The following is a description of a gene set: Genes predicted to be targets of miRBase v22 microRNA hsa-miR-4761-3p in miRDB v6.0 with MirTarget v4 prediction scores > 80 (high confidence targets). from publication Chen Y, Wang X (PMID 31504780) Human Gene Set: MIR4761_3P studied in species Homo sapiens, and this is the list of marker genes: DMRT3, OSBPL1A, TENT5A, KBTBD2, CHCHD7, CFAP91, PRR32, NT5DC1, ARPP19, DESI1, PPP3CA, LHCGR, FAM170B, PUM2, BCL2L2, USP42, CCNL1, BIRC6, ZNF655, RIMS2 (regulating synaptic membrane exocytosis 2), B3GALNT2, EMX2, INO80D (NCBI Gene Id 54891), ERBB2, MAPK8, CPEB4, CACNB4, CDK2AP2, RIC8B, SCGB3A2, SLC16A14 (solute carrier family 16 member 14), CACNG8, HLA-DPA1, DGKH, LRRC39, ZNF709, SRP14, ALS2, RAB25, PTPRB, IL1R1, ERBIN, NABP1, PRLHR, STEEP1, RB1CC1, KDM5A, EIF4G2, FAR2, TMEM116, UBE2Z, SNTG1